Given this list of marker genes H3C15, EHMT1, SETD6 (NCBI Gene Id 79918), SMYD3, AEBP2, EED, KMT5A, H3C1, ASH2L (NCBI Gene Id 9070), SETDB1, PRDM16, RELA, PRDM9, SETD7, SETD3, NFKB2, SMYD2, RBBP5, SETD1A, KMT5C, SUV39H1, ASH1L, EHMT2, SETD2, NSD3, SUZ12, DPY30, SETDB2 (NCBI Gene Id 83852), EZH2, KMT2D, ATF7IP, KMT2A, DOT1L, KMT5B, RBBP4, KMT2B, H4C1, SETD1B, SUV39H2, NSD2, RBBP7, NSD1, KMT2C, NFKB1, WDR5, MECOM (NCBI Gene Id 4197), here is a description of the gene set: Lysine methyltransferases (KMTs) and arginine methyltransferases (RMTs) have a common mechanism of catalysis. Both families transfer a methyl group from a common donor, S-adenosyl-L-methionine (SAM), to the nitrogen atom on the epsilon-amino group of lysine or arginine (Smith & Denu 2009) using a bimolecular nucleophillic substitution (SN2) methyl transfer mechanism (Smith & Denu 2009, Zhang & Bruice 2008). All human KMTs except DOT1L (KMT4) have a ~130 amino acid catalytic domain referred to as the SET domain (Del Rizzo & Trievel 2011, Dillon et al. 2005, Herz et al. 2013). <br><br>Some KMTs selectively methylate a particular lysine residue on a specific histone type. The extent of this methylation (mono-, di- or tri-methylation) also can be stringent. Histone literature typically refers to specific residues by numbers which are determined after the initiating methionine has been removed. First to be discovered were the SUV39 family named after founding member SUV39H1 (KMT1A), which selectively methylates lysine-10 of histone H3 (H3K9). Family member EHMT2 (KMT1C, G9A) is the predominant H3K9 methyltransferase in mammals. SETDB1 (KMT1E, ESET) also predominantly methylates H3K9, most effectively when complexed with ATF7IP (MCAF, hAM). <br><br>SETD2 (KMT3A, HYPB), a member of the SET2 family, specifically methylates histone H3 lysine-37 (H3K36). WHSC1 (KMT3G, NSD2, MMSET) a member of the same family, targets H3K36 when provided with nucleosome substrates but also can methylate histone H4 lysine-45 when octameric native or recombinant nucleosome substrates are provided; dimethylation of histone H3 at lysine-37 (H3K36me2) is thought to be the principal chromatin-regulatory activity of WHSC1. Relatives NSD1 (KMT3B) and WHSC1L1 (KMT3F, NSD3) also methylate nucleosomal H3K36. NSD1 is active on unmethylated or a mimetic monomethylated H3K36, but not di- or trimethylated H3K36 mimetics. Human SETD7 (KMT7, SET7/9), not classified within the 7 SET-domain containing families, mono-methylates lysine-5 of histone H3 (H3K4). Reactome Pathway: PKMTs methylate histone lysines part of: Chromatin modifying enzymes studied in species Homo sapiens